The following is a description of a gene set: A nonprogressive (i.e., stationary) form of difficulties with night blindness with congenital onset. Congenital stationary night blindness studied in species Homo sapiens Human Gene Set: HP_CONGENITAL_STATIONARY_NIGHT_BLINDNESS, and this is the list of marker genes: PDE6B, RHO, GRK1, GPR179, TRPM1, CACNA1F, LRIT3, SLC24A1, NYX, TRAPPC9, RDH5, RLBP1, SAG, GNB3, MYO6, FGFR2, GRM6, PRPH2, CACNA2D4, CABP4, GNAT1